Given this list of marker genes KLHL22, EP300, MTOR, UBR2, LARS1, STAMBPL1, RRAGD, SESN1, UBR1, RPTOR, SESN2, SESN3, here is a description of the gene set: species: Homo sapiens Human Gene Set: GOBP_CELLULAR_RESPONSE_TO_L_LEUCINE Any process that results in a change in state or activity of a cell (in terms of movement, secretion, enzyme production, gene expression, etc.) as a result of a L-leucine stimulus.